The following is a description of a gene set: Human Gene Set: HP_PAPULE studied in species Homo sapiens A circumscribed, solid elevation of skin with no visible fluid, varying in size from a pinhead to less than 10mm in diameter at the widest point. Papule, and this is the list of marker genes: COL5A2, TMC8, KIT, LPIN2 (lipin 2), SUFU, STAT4, ELOVL4, SEC23B, XPA, COL14A1, KLRC4, KLLN, MVK, TLR4, KRT14, NLRP3, GJB2, CLEC7A, IL17F, PRTN3, NAGA, SDHD, PTPN6, CARD14, STAT3 (signal transducer and activator of transcription 3), NF1, XYLT2, PEPD, ATP2A2, KRT1, PRDM10, XYLT1 (xylosyltransferase 1), PIGA, ERCC4, MEFV, HLA-DPA1, CIB1, SLC17A9, FLNA, CCR1, PLEC, CFTR (NCBI Gene Id 1080), AEBP1, CSTA, PTEN, IL23R, FAS, CYLD, GGCX, MBTPS2, CTLA4, EGFR, IL10, AKT1, SDHC, PTPN22, DCLRE1C, ENPP1, HAVCR2, POGLUT1, UBAC2, BRAF, TGM5, LMNA, C4A, PIK3CA, FLCN, NOD2, POFUT1, IL17RA, THBS2, SDHB, AAGAB, COL7A1, IDH1, IL17RC, KRT5, ERAP1, GNAQ, IFNGR1, GNAS, IL7, IL12A, ZMPSTE24, ABCC6, HLA-B, COL1A1, HLA-DPB1, PSENEN (NCBI Gene Id 94939), LDHA, ANTXR2, USF3 (NCBI Gene Id 205717), TRAF3IP2, TMC6, ECM1, GJB6, LRP1, IL12A-AS1, AQP5, COL5A1, GLMN